Given this list of marker genes HNRNPA1, QRICH2, HNRNPA2B1, RPGR, CEL, HSPB3, PLCZ1, CNTNAP2, SLC7A6OS, PRRT2 (NCBI Gene Id 81865), TPP1, LHB, CAPN1 (NCBI Gene Id 823), EXTL3, STRC, AURKC, FHL1, GNPTAB, P2RX2, CEP78, ANO5, GNB4, HTRA1, ALDH18A1, VAMP1, B2M, TLR7 (toll like receptor 7), FARS2, IQCN, SLC26A1, CTSF, CAPN3 (NCBI Gene Id 825), SGO1, AIP, FLNC, CHRNA2, GABRA3, PSEN1, TP53, SNORD118, AFG3L2, SPG11, PRDM10, TRNT1, APOA1, NEK8, MICAL1, NLRP3, PRKAR1A, MCM6, MAPKAPK3, SLC22A12, VCY, PLG, CASQ2, BLK, RP1, TRPV4, KLHL3, LIG3, GDF9, POT1, THSD4, NLRP7, SLC19A3, BRDT, SYCP2 (NCBI Gene Id 10388), PCYT1A, CFAP61, BPY2, PKD2, HFM1, EPAS1, RRM2B, CASK, KCNU1, STOX1, MYL4 (NCBI Gene Id 4635, myosin light chain 4), MME, TERB1, UNC13D, ATP11A, KLHL24 (kelch like family member 24), SPTAN1, DSG2, PRNP, ERCC6L2, PTEN, MPV17, FBN1, RFXANK, BRCA2, CHEK1, CHRNA1, SNCA, SCN1A, DIABLO, DNM1L (dynamin 1 like), PRPF4, ESR2, WNT4, CCND1, MAPT, MAPKBP1, FKBP6, MMACHC, NOTCH3, BVES, PRLR, FN1, FDPS, TRIP13, SHOC1, ATP7B, SDHD, CD164, RAB39B, RBMY1A1, TNNT1, BAP1, VSX1, SPTLC2, CSF1R, NEFL, PPP2R3C, SEPTIN12, KCNJ5, CFAP44, DNMT1, ATP1A2, HSFY1 (NCBI Gene Id 86614), COQ8B, GDAP2, EPHA10, MYBPC3, STT3A, ACTN2, CNNM2, GCK, SAMD7, MEFV, RYR2, SMN2, SCARB2, CTNNA1, HAMP, MANF, TECRL, NDUFS2, NPHP1, AARS2, VPS13D, MSH4, OXGR1, STAT1, TIE1, VHL, MEI1, TP63 (NCBI Gene Id 8860), TTLL5, LAMA4, DHTKD1, MAFB, GALC, YARS1, DYRK1B, MEIOB, GBF1, PNLDC1, CARD9, NPPA, CYP27A1, SLC4A11, DNAJB2, G6PD, PIK3R5, MSH5, WRN, ITPR3, ABCA4, TRMT5, PMVK, DAZ2, MYZAP, PMP2, SLC17A9, IMPG2, TULP3, FBLN5, JAG2, GFAP, SRPK3, PDGFB, TYROBP, ERCC6, UMOD, KLHL7 (kelch like family member 7), ANO3, GAA, AOPEP, CATSPER2, SOHLH1, IDS, CPT2, TOR1AIP1, NOL3, VPS16, ATP13A2, PRPF8, SMARCA4, PRKN, ANXA5, KCNQ1, SLC34A2, NAGLU, SSX1, SUN5, H6PD, PRKAG2, FSHB, DSP, KCNJ18, RNF216, TSGA10, TAF4B, ELOVL5, KCNK3, MATR3, YEATS2 (YEATS domain containing 2), ARL2BP, REEP1, CFAP251, SCN5A, NAF1, USP9Y, SMPX, CTNS, EPCAM, SOX9, APPL1, DGUOK, PLIN1, REEP6, ARHGEF18, PDHA2, CC2D2A, ALG10B, HAVCR2, CEBPE, DRC1, DNAH1, ATL1, XRCC1, NF2, PAX4, COL2A1, SYCP3, PRKRA, ATP6AP2 (ATPase H+ transporting accessory protein 2), MYPN, KCND3, PKP2, DNHD1, TRRAP, DAZ3, TEX15, SPACA1, CACNB4, ATP1A3, HKDC1, ANLN, TIA1, RBM12, PLAAT3, ANXA11, CDY1, GCNA, PRPH2, SOCS1, NT5C2, ALDH5A1, TBX18, SOST, TDRD9, SEC23B, GANAB, AK7, FANCM (FA complementation group M), SNTA1, ASTL, RPL10L, JAK2, SMN1, PRPF6, VPS13A, PSEN2, SERPING1, LGI1, ATL3, JPH2, MYH6 (NCBI Gene Id 4624), HSPB1, SPINK2, SLC39A14, ZFP36L2, AAGAB, ADGRG2 (adhesion G protein-coupled receptor G2), IL36RN, TIMP3, WEE2, BMPR2, SYCP2L, KIF5A, MARS2, SEC61A1, LPL, EIF2B3, LMNA, NAGA, VEZF1, CLN6, CYP7B1, CFI, CDH2, CCIN, KCNA5, FSIP2, RPS19, KCNJ2, ABHD12, SELENBP1 (selenium binding protein 1), ACTA1, MGME1, CLCN2, SLC4A1, NPTX1, ACR, LBR, RBM20, HSPB8, RILPL1, SHANK3, ZSWIM7, CCDC34, MECR, ENG, SAMD9L, GGN, SMPD1, NR0B1, TEX14, F2, TTC21A, SMAD2, KASH5, MOV10L1, TBX3, DIAPH3, PSAP, FOXL1, TTN, PDGFRB, TRIM32 (NCBI Gene Id 3971), KNG1, TMEM126B, VPS13C, PLA2G6, BAG5, CATSPER1, SETX, TGFBI, TUBB4A, ELOVL4, XKRY, GIPC1, RPS4Y2, MBD4, PATL2, HPRT1, TERB2, RNASEH1, SLC26A8, PRDM16, DNAJB6, CIB1, CRYBA2, CDY2A, SSBP1, OBSCN, SPATA22, ICOS, CACNA1A, HK1, MORC2, CCDC39, VCL, PMP22 (NCBI Gene Id 5376), SLCO2A1, SCNN1G, NR3C1, POF1B, ITM2B, HNF1B, POGLUT1, FOXC1, AMACR, SH3BP2, AARS1, GPIHBP1, MYH7, RP1L1, GARS1, DNAJC30, NHLRC1, MFRP, TERT (NCBI Gene Id 7015), KCNH2, KCNC3, GJC2, XRCC2, TMEM43, COL6A3, PKHD1, CHD8, ELMOD3 (ELMO domain containing 3), NR2E3, TNNT2, PDE11A, LIPE, ATXN3, CAPNS1, WASHC5 (WASH complex subunit 5), KCTD17, MFN2, CAV1, PTF1A, THAP1, PPOX, ANO10, DNALI1, DAB1, SEMA3A, CCDC62, RAF1, UBQLN2, ATN1 (NCBI Gene Id 1822), CDC20, CMPK2, SPRY2, OPTN, INS, ATXN10, CCDC146, ZNF408, KCNJ11, PANK2, TAF4, CASR, INF2, RRAGD, CLDN16, CPOX, TRDN, STK33, ZP3, DES, CBFB, CYLD, B4GALNT1, MFSD8, GATA2, TWNK, COQ4, MOS (MOS proto-oncogene, serine/threonine kinase), GRN, COL4A1, NRL, ACTL7A, TENM4, LMX1B, LYZ, TNNI3, EIF2AK2, CFAP43, IFT140, TRPM3, TLCD3B, PRDX1, PPARG, PRDX3, HINT1, SGCD, SLC2A10, DTNA, MAFA, RIGI, MARCHF6, RP2, SLC19A2, SUFU (NCBI Gene Id 51684), DNAJC5, CLCN1, TNNC1, LRP12, SYCE1, NEXN, IFT74, STAG3, DYSF, C14orf39, SPAG17, USP26, HGSNAT, VAPB, KCNE1, SPTLC1, BAG3, SLC4A3, DNAJB4, DIAPH2, SERPINH1, RET, LMF1, HJV, PLN, MAP1B, RAX2, TRPC6, CT55, NLRP5, CAV3, NLRP2 (NLR family pyrin domain containing 2), LOX, FBXO43, MAK (NCBI Gene Id 4117), ATP6V0A1, RIPOR2, TBP, SLC12A5, ITPR1, DNAH17, ACTG1, LYST, C2CD6, KDM5D, SLC37A4, ERLIN2, WDR19, FIG4, POLG, SCN4A, DPY19L2, IFIH1, F5, CFH, EIF2AK4, NRCAM, TINF2, MOG, PNPLA6, COCH, SCN3B, CATIP, C19orf12, USP48, CYLC1, CHCHD10, MCAT, HCN4, SLC44A4, DRAM2, MSH3, POLRMT, DNA2, NAA60, ZMYND15, HROB, TEX11, VCP, RRM1, IKZF1, GYG1, APC, GGCX, NF1, DGKE, AKAP3, RELN, DAZ1, NOTCH2NLC, LRRC23, KPNA7, POLG2, FKTN, SLC25A4, INSR, SPG7, ZPBP, TPM1, TLR8, MAGT1, DNAJC3, TTBK2, DDX3Y, SFTPA1, ACTC1, NPC1 (NCBI Gene Id 4864), AAAS, SLC4A4, TNC, ZP1, ARMC12, BBS2 (NCBI Gene Id 583), TBC1D24 (NCBI Gene Id 57465), VPS11, ATXN2, SYNJ1, DSC2, SERPINA1, TNFAIP3, here is a description of the gene set: Human Gene Set: HP_YOUNG_ADULT_ONSET species: Homo sapiens Young adult onset Onset of disease at the age of between 16 and 40 years.